The following is a description of a gene set: Blepharophimosis A fixed reduction in the vertical distance between the upper and lower eyelids with short palpebral fissures. Human Gene Set: HP_BLEPHAROPHIMOSIS species: Homo sapiens, and this is the list of marker genes: ERCC6, ANK1, BRCA1, ZMPSTE24, MECP2, RAB18, HUWE1, MAPK1, STRA6, MUSK, CDK13, RBMX, SLX4, EIF4H, CLIP2, PHF6, SOX9, TBX15, RERE, VPS37D, TP63, RNU4-2, UGDH, TBL1XR1, GPKOW, RECQL4 (RecQ like helicase 4), HDAC4, EP300, DDR2, MCTP2, DNAJC30, PIEZO2, TBX1, ATP6V1E1, TMEM270, DGCR6, MED12, LIMK1, TBL2, ORC1, GTF2I, ALG14, MYCN, ERCC1, METTL27, CREBBP, MYL11 (NCBI Gene Id 29972), CHN1, SLC2A10, GJA1, BUD23 (BUD23 rRNA methyltransferase and ribosome maturation factor), KAT6B, CRKL, ALX4, WDR35, SEPTIN9, PRIM1, RIPK4, GTF2IRD2, NSUN2, SMOC1, HSPG2, MAFB (MAF bZIP transcription factor B), CTCF, CEP152, MAPRE2, COLEC10, CUL4B, UBE3B, RFC2, ODC1, DGCR2, DCHS1, TXNL4A, KRAS, TUBB, ZFX, MASP1, BCR, FKBP6, PAX3, DNMT3A, BCOR, TRAF7, RHOA, DACT1, KCTD1, COLEC11, SMO, STAC3, RTL1, NCF1, SMARCA2, TBC1D2B, SALL4, KMT2A, SETD5, ESS2, STX1A, BRPF1, HNRNPH1, LIG4, GATAD2B, GTF2IRD1, SMAD4, KANSL1, ATP6V1A, MOGS (NCBI Gene Id 7841), IRX5, FANCD2, SF3B2 (NCBI Gene Id 170474), FAT4, MEG3, DLK1, ATR, ELN, FOXL2, BAZ1B, NFIB, DGCR8, MYH3, TLK2, SALL1, HHAT, CEP57, MLXIPL, FOXG1, GPC6, KCNJ2, FOXP1, SCARF2